Given this list of marker genes Ccnb1, Tefm, Atp5f1e, Cox6a2, Ndufb2, Ndufa7, Ndufc2, Ndufa13, Uqcc2, Cox7b2, Iscu, Cox6b1, Uqcrb, Actn3 (NCBI Gene Id 11474), mt-Co1, Nupr1, Stoml2, Cox8a (NCBI Gene Id 12868), Cyc1, Cox5b, mt-Nd3, mt-Nd6, Atp5pf, Ndufb11, Sdhb, Atp5pb, Abcd1, Atp5f1d, Myog, Atpsckmt, Mtch2, Ndufs3 (NCBI Gene Id 68349), Slc25a23, 1700066M21Rik, Shmt2, Ndufb10, Pink1, mt-Nd5, Cox6b2, mt-Co2, Slc25a51, mt-Atp6, Atp5f1c, Ak4, Ndufv3, Cdk1, Sdhc, Vcp, Ndufa8, Nipsnap2, Uqcr10, mt-Co3, Ndufa10, mt-Nd4, Cox7a2, Cox5a, Fxn, Ndufc1, Uqcr11, Ndufaf1, Ndufa6, Ndufa2, Cox7a1, Atp5if1, mt-Cytb, Sdha, mt-Nd4l, Ndufv1, Ndufb1 (NCBI Gene Id 102631912), Cox7b, Slc25a33, Ccnb1-ps, Apoc3, Ndufb3 (NADH:ubiquinone oxidoreductase subunit B3), Tnf, Cox8c (NCBI Gene Id 75483), Atp5mf, Ndufs7, Rhoa, Park7, Cox6a1, Ndufb5, Cox7a2l, Atp5me, Uqcrfs1, Atp5pd, Atp5po, Ndufa5, Cox4i1, Mir451a, Chchd2, Ndufs2, Ndufs6, Cox4i2, Uqcrc1, Snca, Atp6-ps, Dguok, Tafazzin, Ndufs8, Dnajc15, Ndufb6, Uqcrc2, Chchd10, Ndufab1, Cyct, Ndufa3, Ppif, Atp7a, Bdnf, Sdhaf2, Afg1l, Ndufb4, Bcl2l13, Mir451b, Mlxipl, Pde2a, Uqcrh, Uqcrq, Atp5f1a, Ndufb9, Myc, Ndufa12, Dld (NCBI Gene Id 13382), mt-Nd1, Msh2, Antkmt, mt-Atp8, Ndufb7, Ndufa11, Ndufs4, Cox8b, Ndufs1, Bid, Cox6c, Cox7c, Coq9, Macroh2a1, Chchd2-ps (NCBI Gene Id 433806), Uqcc3, mt-Nd2, Atp5f1b, Tmem135, Coa6, Sdhd, Ndufv2, Coq7, Ndufa1, Cycs, Ndufb8, Dnajc30, Ndufa9, Ndufs5, here is a description of the gene set: Mouse Gene Set: GOBP_OXIDATIVE_PHOSPHORYLATION species: Mus musculus The phosphorylation of ADP to ATP that accompanies the oxidation of a metabolite through the operation of the respiratory chain. Oxidation of compounds establishes a proton gradient across the membrane, providing the energy for ATP synthesis.